The following is a description of a gene set: Human Gene Set: GOBP_ORGANIC_ACID_BIOSYNTHETIC_PROCESS studied in species Homo sapiens The chemical reactions and pathways resulting in the formation of organic acids, any acidic compound containing carbon in covalent linkage., and this is the list of marker genes: GGTA1, MIR96, ACSM4, LDHC, PNLIPRP2, GAMT, CYP2C8, NAIP, ACSM2B, AKR1C3, NR1H3, PRKAB2, CYP4A22, SCD5, BRCA1, GLUL, DCAF5 (DDB1 and CUL4 associated factor 5), ALOX12B, CLN3, OTC, MIR30C1, EDN2, OSBP, DHRS9, GSTM4, LTC4S, DEGS1, CYP39A1, MIF, LIPG, GSTM2, ABCB11 (NCBI Gene Id 8647), FABP5, PLA2G5, PHGDH, ACOT4, STAR, GLS2, CSAD, ASAH2, PNLIPRP1, NANS, PECR, ELOVL5, ALDH18A1, ACSM3, NANP, KLHL25, MIR766, APOC3, PYCARD, ACSS2, FADS3, WDTC1, CYP2E1, SLC38A1, ALDH1A3, PRKAG2, IDO1 (NCBI Gene Id 3620), GNE, PYCR2, MECR, FGFR4, FGF19, PLP1, SCD, ELOVL6, PLA2G4A, TECR, APOC2, SLC1A3, SHMT2, GGT2P, PTGIS, PNLIPRP3, CBR1, BHMT, CDO1, ACOX1, GGTLC2, MLYCD, EHHADH, ATP2B4, CPS1, CASP1, CYP2C9, HAO1, CYP4F11, ABCD1 (ATP binding cassette subfamily D member 1), ASNSD1, GGT1, BAAT, GSTP1, SYK, APOC1, SCP2, ACSBG1, AGXT2, ERLIN1, BCAT2, HSD17B10 (NCBI Gene Id 50828), SERINC5, SCAP, ENSG00000274276 (NCBI Gene Id 102724560), PRG3, AKR1C4, ENOPH1, ALDH1A2, HTD2 (NCBI Gene Id 109729165), MTHFD1, MTHFD2, ELOVL1, CAD, BHMT2, THNSL2, PRXL2B, UBR4, CYP7B1, UGP2, PNLIP, ACSF3, TECRL, PTGES3, RDH10, PDK4, DPYD, MGLL, PTGS1, ACSM2A, NAGS, GLS, CYP4A11, LGSN, OSBPL1A, EDN1, OSBPL3, MALRD1, FADS1, MTHFD1L, FADS2, PCBD1, HACD1, STARD4, HSD17B4, ACSS1, PRMT3, PSAT1, HACD4, GATD1, GGTLC1, CYP2D6, IL1B, ADI1, ALOX15, OSBPL6, HSD17B12, SEPHS2, APOA5, SHMT1, ELOVL3 (ELOVL fatty acid elongase 3), HSD17B8, AMACR, ABCD3, ACSM1, OSBPL7, PYCR1 (NCBI Gene Id 5831), SRR, ALOX12, MIR182, HPGDS, MGST3, BCAT1, PKLR, GGTLC3, MIR132, PRKAA2 (NCBI Gene Id 5563), TRIB3, NOXRED1, GSTM1, ALOXE3, GGT3P, PYCR3, GATM, MTR, PARK7, CD74, SERINC3, MGST2, ALDH1A1 (NCBI Gene Id 96075), CTH, GGT6, GPIHBP1, ALOX5AP, GLUD2, GIP, NDUFAB1, HSD3B7, PSPH, GAD2, TMEM135, MLXIPL, FMO3, ASL, OSBPL9, SIRT1, SLC27A2, ABHD1, HOGA1, UPB1, NLRC4, LTA4H, ACACB, NR1D1 (nuclear receptor subfamily 1 group D member 1), CEACAM1, DAGLB, ALOX15B, PTGS2, LPL, PRKAG1, FASN, KYNU, MIR33A, CYP7A1, ABCD2, NR1H2, PRKAA1, MTRR, CTHRC1, ERLIN2, PROX1, HACD3, PLA2G4F, PIBF1, SDS, ELOVL4, PER2, MIR185, MID1IP1, MIR342, FMO1, PRKAG3, HACD2, KMO, PAH, ACADL, LIPC, GOT2, MIR548P, ASNS, CYP1A1, EIF6, PTGES, SLC27A5, APOA4, ALDH8A1, HAAO, CBS, KAT2B, PRKAB1, ACSL1, PLA2G1B, ABHD3, PNPLA8, ACLY, PLOD2, ALOX5, NR1H4, GLUD1, GGT5, FADS2B, ACOX2, ACSBG2 (acyl-CoA synthetase bubblegum family member 2), GPX4, OAT, AVP, MCAT, SIRT2, PLA2G10, ELOVL7, AGXT, CYP3A4, CARNS1, LIAS, SUCLA2, QKI, OXSM, PLA2G3, ABAT, ELOVL2, GOT1 (NCBI Gene Id 2805), ACMSD, CYP8B1, APIP, CES1, PTGES2, DECR2, LPGAT1, GGT7, ACSM6, MIR204, UGDH, GAD1, SEPHS1, ACOT7, SLC45A3, TBXAS1, ACSL4, INSIG1, AKR1D1, RBP1, CYP27A1 (NCBI Gene Id 1593), OLAH, ACOT8, FADS6, CBR4, OSBPL2, PLAA, PTGDS, AVPR1A, ABHD2, ACADVL (acyl-CoA dehydrogenase very long chain), PLOD3, FA2H, GOT1L1, UROS, INSIG2, ACSM5, XBP1, ACACA, CYP46A1, ERRFI1, ANGPTL4, ASS1, CYP1A2